Given this list of marker genes B3GALT5, ABO, B3GALT2, FUT2, B3GNT5, B3GALT1, here is a description of the gene set: Blood group H (O) antigen type 1 biosynthesis. Pathway ID: N01651. Pathway type: Reference. Pathway class: nt06035 Blood group carbohydrate antigen biosynthesis. studied in species Homo sapiens Human Gene Set: KEGG_MEDICUS_REFERENCE_BLOOD_GROUP_H_O_ANTIGEN_TYPE_1_BIOSYNTHESIS Pathway Definition from KEGG: LacCer -- >> B3GALT1/2/5 -> Lc4Cer -- FUT2*H -> TypeIH // ABO*O